Given this list of marker genes L2HGDH, TXNDC16, SNX2, GOT1, WNT6, FZD5, GRK5, MATN2, SLC22A5, CENPV, HHAT, TBCCD1, SH3PXD2B, RHCG, GRAMD2B, NIT2, PLEKHA8, CXXC4, SPTBN1, TMEM31, PLPP6, MTERF2, ZNF25, FLNA, HBB, CCDC6, ANXA1, PPP1R15B, RASSF7, MIPEP, COL23A1 (collagen type XXIII alpha 1 chain), TMEM87B, SEC24D, LAG3, DENND2C, CHRM3, COPZ2, ACCS, DMAC1, P3H2, KLF6, TTL, ARMC12, TCERG1L, RASL11B, PTGR3, SLC5A4, PPP1R36, OPN3, RTN4, ABCA3, ARPP21, BANF2, BAG2, CAPN8, MAN1A2, SLC5A3, CTSE, LAP3, STXBP5, TBCA, NIBAN1, SYT1, PSAT1, ANGEL1, FICD, PRRT1, SYNE1, SOX2-OT, ROCK1, SPINK8, TTC7B, STAB2, GIPC3, KCNN4, ALDOC, MAL, ST13, C9orf72, SOHLH2, PPP1R26, FMNL2, FOXO1, CACNB2, SPTLC1, LRRC18, SLC35E4, PHKA2, PPFIBP1, TSPAN33, CCNB1IP1, GALC, LEPROTL1, SEPSECS, HM13, FAT1, RIMOC1, PLXDC1, OXCT1, CARD19, CAMK1D, MPZL2 (myelin protein zero like 2), PWWP2B, SOD1, DNAH17, STRADB, MROH1, RCVRN, MRPL42, EIF2A, MORC2, QPCT, NUP93, SP5, STRIP2, UCP3, CCNH, FAM149A, KHK, AP1B1, SPATS2L, PEDS1, INTS4, SYNRG, SYT2, RHBDF1, MTSS1, RNF19A, JPT2, SH3GL3, CAMSAP3, SLC9A9, PGK1, RBPJ, CD8B, CMTM8, DBH, CTLA4, CSDC2, MYCL, ZDHHC20, UBE3A, TSSK2, IL17RD, SLC5A5, ASAH2 (NCBI Gene Id 63292), TAF5L, PPM1H, PSAP, GPRC5C (NCBI Gene Id 55890), MLLT3, NDST2, RASA3, DUBR, PFKP, LITAF, NAA25, AFF1, LEFTY1, MAGED1 (NCBI Gene Id 9500), SLC22A15, SLC19A2, TTC39A, FASTKD1, CASP3, ENPP4, RWDD1, MST1, SLCO3A1, CYB5R1, WNT9A, CD207, G6PC3, ZDHHC23, MYOF, VIM, ARHGAP21, MINDY3, AFF3, NDUFS2, KCMF1, HES3, RNF180, SNAP29, ATP8A1, GAS2L1, ITM2A, NEUROD1, CD44, DTNB, CCKBR, KCTD6, RNH1, FUCA1, CD86, GALNTL5, C3orf70, SH3RF1, MRPS5, here is a description of the gene set: To obtain insight into the genetic basis of the increase of functional activity of memory B cells over time, we compared the gene expression profiles of day 7 and day 40 NP-specific/IgG1 memory B cells, GC B cells and plasma cells in immunized WT mice and naïve B cells, before and after activation in vitro. Human Gene Set: GSE11961_MEMORY_BCELL_DAY7_VS_MEMORY_BCELL_DAY40_UP from publication Kaji T, Ishige A, Hikida M, Taka J, Hijikata A, Kubo M, Nagashima T, Takahashi Y, Kurosaki T, Okada M, Ohara O, Rajewsky K, Takemori T (PMID 23027924) studied in species Homo sapiens Genes up-regulated in day 7 memory B cells versus day 40 memory B cells.